The following is a description of a gene set: studied in species Homo sapiens Human Gene Set: GOCC_HIPPOCAMPAL_MOSSY_FIBER_TO_CA3_SYNAPSE One of the giant synapses that form between the mossy fiber axons of dentate gyrus granule cells and the large complex spines of CA3 pyramidal cells. It consists of a giant bouton known as the mossy fiber expansion, synapsed to the complex, multiheaded spine (thorny excresence) of a CA3 pyramidal cell., and this is the list of marker genes: SUMO2, LRRTM2, YWHAZ, RAPGEF4, EPHB2, STXBP5, CAPZB, GRIK4 (glutamate ionotropic receptor kainate type subunit 4), CALCA, SLC6A9, SLC16A7 (solute carrier family 16 member 7), C9orf72, GRIK2, CALB1, BACE1, ADCY1, ADCY8, AKAP7, SYT7, PDYN, DTNBP1, SYT9, EPHA7, GRIK5, SLC39A3, IGSF8, GPER1, SYT12, CACNG2, ROGDI, SYT1, CTNNA2, P2RX3, LNX1, NECTIN1, C1QL3, EFNB3, NECTIN3, GRIN2D, C1QL2, SLC30A3, PTPRD, PPP3R1 (protein phosphatase 3 regulatory subunit B, alpha), GNAI2, NAPEPLD, PRKAR1B